The following is a description of a gene set: PKA-mediated phosphorylation of key metabolic factors species: Homo sapiens Human Gene Set: REACTOME_PKA_MEDIATED_PHOSPHORYLATION_OF_KEY_METABOLIC_FACTORS, and this is the list of marker genes: PRKACB, PRKACG, PRKACA, MLXIPL, PFKFB1